The following is a description of a gene set: Mouse Gene Set: CUI_CDC2_IL7_RESPONSE_UP Cytokines mediate cell-cell communication in the immune system and represent important therapeutic targets. A myriad of studies have highlighted their central role in immune function, yet we lack a global view of the cellular responses of each immune cell type to each cytokine. To address this gap, the authors created the Immune Dictionary, a compendium of single-cell transcriptomic profiles of more than 17 immune cell types in response to each of 86 cytokines (>1,400 cytokine-cell type combinations) in mouse lymph nodes in vivo. A cytokine-centric view of the dictionary revealed that most cytokines induce highly cell-type-specific responses. For example, the inflammatory cytokine interleukin-1β induces distinct gene programmes in almost every cell type. A cell-type-centric view of the dictionary identified more than 66 cytokine-driven cellular polarization states across immune cell types, including previously uncharacterized states such as an interleukin-18-induced polyfunctional natural killer cell state. species: Mus musculus from publication Cui A, Huang T, Li S, Ma A, Pérez JL, Sander C, Keskin DB, Wu CJ, Fraenkel E, Hacohen N (PMID 38057668) Genes positively differentially expressed in cell type: cDC2 (conventional dendritic cell type 2) upon treatment with cytokine: IL-7 in mouse lymph nodes in vivo., and this is the list of marker genes: Slfn1, Ddx39a, Ccdc86, Rrbp1, Slc30a4, Mrps18b, Stat1, Plpbp, Cd274, Tgfb1 (NCBI Gene Id 21803), Cacybp, Ogfr, Slfn2, Napsa, Eif5a, Irf5, Nod1, Cltc, Cdk2ap2, Cyp4f16 (NCBI Gene Id 70101), Il1rn, Ms4a6d, Rpf2, Ifi207, Vasp, Atp2c1, Ms4a4c, Bbip1, Bcl3, Dynll1, Adam8, Trim30d, Lamtor3, Ly6a, Ifih1, Lcp2, Eif2ak2, Rab3il1, Il21r, Ptges3, Srsf9, Lair1, Cyrib, Fyn, Syngr2, Tnip3, Cd300lf, Fgr, Actr3, Nip7, Pnp, Hspa5, Ccl12, Ccnd3, Cd53, Cdkn1a, Cflar, Isg15, Pim1, Rigi, Hspa9 (heat shock protein 9), Ifi205, Lfng, Ier3, Cyba, Ehd1, Lcp1, Bcl2 (NCBI Gene Id 98734), Fabp5, Tuba4a, Eif4a1, Frmd4b, Rap2a, Irf4, Sdc4, Zbp1, Myo1e, Hspa8, Nlrp3 (NCBI Gene Id 216799), Srsf2, Spint1, Efhd2, Irf7, Ctsz (cathepsin Z), Cst3, Tpm3, Nampt, Prkcd, Ly6e, Sdc3, Nr1h3, Pfkp, Serpina3g, Mrpl20, Scimp, Arpc1b, Ifi211, Hck, Clec4n, Asb2, Fcgr1, Pfn1, Adar, Ptpn1, Bcl2a1b, Vrk1, Cd40, Marcksl1, Exosc3, Trio, Hspa4, Ran, Ifi47, Dok2, Pdlim4, Ifi204, Trim30a, Txnrd1, Socs3, Hsp90b1, Oasl2, Mndal, Plek, Spi1, Tarm1, Sumo1, Rnf19b, Eif1, Calr, Apobec3, Rars1, Snx2, Ak2, Slfn5, Tgfbi (transforming growth factor, beta induced), Cdh1, Bcl2a1d, Tuba1b, Ccl17, Rap1a, Bcl2a1a, Calm1, Xbp1 (X-box binding protein 1), Il4i1, Mat2a, Ifi35